Given this list of marker genes BCO1, LRAT, RPE65, LIPA, RBP2, RLBP1, RBP1 (retinol binding protein 1), ALDH1A2, here is a description of the gene set: species: Homo sapiens The chemical reactions and pathways involving any of the vitamin A compounds, retinol, retinal (retinaldehyde) and retinoic acid, all of which are derivatives of beta-carotene. Human Gene Set: GOBP_VITAMIN_A_METABOLIC_PROCESS